The following is a description of a gene set: Catalysis of the transfer of a xylosyl group from UDP-xylose to an acceptor molecule. studied in species Mus musculus Mouse Gene Set: GOMF_UDP_XYLOSYLTRANSFERASE_ACTIVITY, and this is the list of marker genes: Xylt1, Rxylt1, Xylt2, Poglut2, Gxylt1, Poglut3 (NCBI Gene Id 76515), Gxylt2, Poglut1, Xxylt1